The following is a description of a gene set: studied in species Mus musculus Catalysis of the reaction: NAD(P)H + H+ + 2 ferricytochrome b(5) = NAD(P)+ + 2 ferrocytochrome b(5). Mouse Gene Set: GOMF_CYTOCHROME_B5_REDUCTASE_ACTIVITY_ACTING_ON_NAD_P_H, and this is the list of marker genes: Cyb5r3, Cyb5r4, Cyb5r1, Cyb5r2, Por, Cyb5rl